The following is a description of a gene set: from publication Qi Q, Cavanagh MM, Le Saux S, Wagar LE, Mackey S, Hu J, Maecker H, Swan GE, Davis MM, Dekker CL, Tian L, Weyand CM, Goronzy JJ (PMID 27764254) studied in species Homo sapiens Genes negatively correlated with T cell responses (long term) in peripheral blood mononuclear cell in seniors (50-75) after exposure to Zostavax, time point 1D. Comment: (B) Network of genes informative of long-term responses. Vaccination with attenuated live varicella zoster virus (VZV) can prevent zoster reactivation, but protection is incomplete especially in an older population. To decipher the molecular mechanisms underlying variable vaccine responses, T- and B-cell responses to VZV vaccination were examined in individuals of different ages including identical twin pairs. Contrary to the induction of VZV-specific antibodies, antigen-specific T cell responses were significantly influenced by inherited factors. Diminished generation of long-lived memory T cells in older individuals was mainly caused by increased T cell loss after the peak response while the expansion of antigen-specific T cells was not affected by age. Gene expression in activated CD4 T cells at the time of the peak response identified gene modules related to cell cycle regulation and DNA repair that correlated with the contraction phase of the T cell response and consequently the generation of long-lived memory cells. These data identify cell cycle regulatory mechanisms as targets to reduce T cell attrition in a vaccine response and to improve the generation of antigen-specific T cell memory, in particular in an older population. Human Gene Set: QI_PBMC_ZOSTAVAX_AGE_50_75YO_CORRELATED_WITH_T_CELL_RESPONSES_1D_INFORMATIVE_OF_LONG_TERM_RESPONSES_NEGATIVE, and this is the list of marker genes: LGALS1, KLF2, ENO1, FTL, LILRA5, MRPL41 (NCBI Gene Id 64975), GAPDH, RPS27, CCR2, EEF1A1, IL6ST, ANXA1, CAMK1D